The following is a description of a gene set: studied in species Homo sapiens Human Gene Set: HP_GASTROINTESTINAL_HEMORRHAGE Gastrointestinal hemorrhage Hemorrhage affecting the gastrointestinal tract., and this is the list of marker genes: CTLA4 (cytotoxic T-lymphocyte associated protein 4), PLVAP, F8, SEC63, CYP7B1, CDKN2B, FAS, F9, MSH6, RBCK1, RUNX1, MEN1, ENG, BRCA2, PLOD1, CTNNB1, ATP7A, IL10, GDF2, SDHC, CDKN2C, SEC24C, RREB1, LRP5, PRTN3, CASP10 (NCBI Gene Id 843), MLH1, VWF, SDHA (succinate dehydrogenase complex flavoprotein subunit A), EOGT, NOTCH1 (NCBI Gene Id 54781), CD109, CDKN1A, ARPC1B, PUF60, FGG, LBR, SLC25A13, TBX1, CBL, ASXL1, HIRA, KLRC4, CDKN1B, DOCK6, STN1, C4A, IFNGR1, APC, CHEK2, SLCO2A1, TSC2, PMS1 (PMS1 homolog 1, mismatch repair system component), IKZF1, EPCAM (epithelial cell adhesion molecule), PKHD1, TGFBR2, TTC7A, HPS1, POLE, PIK3CA, PDGFRA, UBAC2, MEFV, EPHB2, MCFD2, IL10RA, SDHB, KRAS, HLA-DPA1, MSH2, POLD1, KIT, BMPR1A, KIF23 (NCBI Gene Id 981), TEK, IL23R, SDHD, STK11, CTC1, RACGAP1, GP1BB, GP9, IL12A-AS1, TREX1, TET2, SRSF2, ACVRL1 (activin A receptor like type 1), CISD2, GFI1B, MYC, JMJD1C, HSD3B7, IRF4, ENPP1, XYLT2, APOLD1 (apolipoprotein L domain containing 1), FGB, TNXB, PTPN22, HLA-B, SERPINE1, ALDOB, F5, ATRX, SEMA4A, HPGD, MVK, SMAD4, MED12, WAS, HLA-DPB1, ATM, PMS2, ERAP1, PTEN, SREBF1, RPS20, POT1, DZIP1L, F11, MUTYH, ARHGAP31, MYD88, TAOK1, ARVCF, LMAN1, TLR4, COMT, TINF2, ABCC6, FGA, AGGF1, IFIH1, ITGA2B, MPI, JAK2, RBPJ, XYLT1, FAH, F2, GP1BA (glycoprotein Ib platelet subunit alpha), PRKCSH, ITGB3, TNFRSF1A, F7, CCR1, GREM1, UFD1, CBS, FCGR2C, RHBDF2, WFS1, ITGA2, STAT4, ARPC5, CALR, DLL4, SHARPIN, WIPF1, F10, TSC1, IL12A, AMACR